Given this list of marker genes Calr, Ranbp6, Nup214, Tmco6, Ipo5, Xpo7, Nup42, Xpo1, Snupn, Ipo4, Ipo9, Nutf2-ps1, Kpna2rt, Kpna1, Ranbp17, Kpna6, Xpo6, Xpo5, Ipo11, Kpna7 (karyopherin subunit alpha 7), Kpna3, Kpna4, Tnpo2, Tnpo1, Kpna2, Nutf2, Kpnb1, Hikeshi, Cse1l (NCBI Gene Id 98761), Eif4enif1, Xpo4, here is a description of the gene set: studied in species Mus musculus Binding to and carrying a cargo between the nucleus and the cytoplasm by moving along with the cargo. The cargo can be either a RNA or a protein. Mouse Gene Set: GOMF_NUCLEOCYTOPLASMIC_CARRIER_ACTIVITY